The following is a description of a gene set: Genes predicted to be targets of miRBase v22 microRNA hsa-miR-4259 in miRDB v6.0 with MirTarget v4 prediction scores > 80 (high confidence targets). from publication Chen Y, Wang X (PMID 31504780) Human Gene Set: MIR4259 species: Homo sapiens, and this is the list of marker genes: SULT1C2, PAX7, APRG1 (NCBI Gene Id 339883), DR1, NPAS3, SERPINH1, HS6ST3, RHOA, RBM18, STMN2, CHST9, RBM25, MARCHF4, KCTD18, NFKB2, FHIT, CTNND1, DCT, PDZD7, CCL28, MYEF2, PALM2AKAP2, ELF2, EIF2B1, DCUN1D4, KLHL7